The following is a description of a gene set: The directed movement of isoleucine, (2R*,3R*)-2-amino-3-methylpentanoic acid, into, out of or within a cell, or between cells, by means of some agent such as a transporter or pore. Human Gene Set: GOBP_ISOLEUCINE_TRANSPORT studied in species Homo sapiens, and this is the list of marker genes: SLC3A2, SLC6A20, SLC43A2, SLC43A1, SLC7A5